Given this list of marker genes E2F8, MICAL1, TRAF1 (NCBI Gene Id 7185), GPR89B, CDYL2, GAREM1, TLR7 (toll like receptor 7), CTPS1, ZC3HAV1L, SPOCK2, MAPRE2, TRIP6, SMIM3, P2RX4, CD300C, MTMR4 (myotubularin related protein 4), SWAP70, PURG, DIP2A, AURKB, ATAD2, LPIN2, DLG1, BLM, ZCCHC18, ERCC6L, FES, ASPA, SPEF1 (sperm flagellar 1), BHLHE40, SMARCD2, SHE, PRKAB2, ARHGAP11A, MIR22HG, BEND3, MYO3B, CMC2, ZDHHC2, CNPY4, TRAIP, FAM185A, ABCA3, WDR11, LRRC49, TIAL1, PGD, CPE, MRPL44, AKAP4, PROS1, LYPD1 (NCBI Gene Id 116372), PITPNB, OSTM1, WEE1, SLC30A2, KCTD6, MIB2, INPP4A, STON1, DNAJB2, SPATS1, ITGA9, BNIP5, FAM199X, ABI2, HPSE, DBP, FURIN, TATDN3, TSPAN2, SSBP3, TUBE1, AGPAT4, PIAS3, TMEM26, CCNE1, GJA1, LRPAP1, CD86, MAP3K5, SERPINB6, WDHD1 (NCBI Gene Id 11169), SOCS2 (suppressor of cytokine signaling 2), RECK, COLEC10, MRC1, KIAA1958, ANXA4, DUSP16 (NCBI Gene Id 80824), MIB1, FCSK (NCBI Gene Id 197258), IKZF4, TNFSF13B, ZNF821, IL2RA, TOR3A, ARHGAP20, GLRX2, POLR1C, RCAN1, ENDOD1, TRPM1, SLC25A14, VGLL4 (vestigial like family member 4), EHD1, RHBDL3, KDM5C, PRG4, TMEM170B, SV2A, IAH1, CBFA2T2, UTF1, SESN2, MEDAG, TMEFF2, C1QA, CCDC150, VAX2, SPRED1, FAM217A, GRN, PFN2, TGM2, MRPS30, RFNG, OXLD1, PTGER2, KRT18, WDR76, EXO1, TRIP4, MTNAP1, DGAT1, SHCBP1, FRMD5, C12orf75, TYMS, PTGER3, COPRS, C1QC, PPM1A, PLPP1, FRMD6, AMPH, SELENBP1, HMGCS1, ARHGAP31, FFAR2, DLGAP5, TCN2, SLC35D2, GPR155, TBL2, TMEM219, B3GLCT, CNPY2, SNX33, PLPP2 (phospholipid phosphatase 2), PARN, TMEM164, ADCY9, MATN2 (matrilin 2), CDKN2C, NCBP3, CDCA2, ATAT1, MGAT5, ANXA2, CENPF, SYCE2, UBASH3B, ZNF329, SYK, MAPKAPK3, FANCD2, BMPR2 (NCBI Gene Id 659), FAM32A, LXN, SNX19, NUP214, PRNP, CCDC6, RTTN, IFIH1, IL17A, STIMATE, PLEKHF1, SYP, USP6NL, PMVK, NEK3, SLC16A10, ABCC4, C1orf198, PRKCA, CDC25B, LZTFL1, CHST11, here is a description of the gene set: from publication Durant L, Watford WT, Ramos HL, Laurence A, Vahedi G, Wei L, Takahashi H, Sun HW, Kanno Y, Powrie F, O'Shea JJ (PMID 20493732) species: Homo sapiens STAT3, an essential transcription factor with pleiotropic functions, plays critical roles in the pathogenesis of autoimmunity. Despite recent data linking STAT3 with inflammatory bowel disease, exactly how it contributes to chronic intestinal inflammation is not known. Using a T cell transfer model of colitis we found that STAT3 expression in T cells was essential for the induction of both colitis and systemic inflammation. STAT3 was critical in modulating the balance of T helper 17 (Th17) and regulatory T (Treg) cells, as well as in promoting CD4+ T cell proliferation. We used chromatin immunoprecipitation and massive parallel sequencing (ChIP-Seq) to define the genome-wide targets of STAT3 in CD4+ T cells. We found that STAT3 bound to multiple genes involved in Th17 cell differentiation, cell activation, proliferation and survival, regulating both expression and epigenetic modifications. Thus, STAT3 orchestrates multiple critical aspects of T cell function in inflammation and homeostasis. Genes up-regulated in CD4 T cells: TGF beta versus TGF beta and IL6. Human Gene Set: GSE21670_TGFB_VS_TGFB_AND_IL6_TREATED_CD4_TCELL_UP